The following is a description of a gene set: Mouse Gene Set: GOCC_DENSE_BODY An electron dense body which may contain granules. species: Mus musculus, and this is the list of marker genes: Sybu, Piwil1, Snd1 (staphylococcal nuclease and tudor domain containing 1), Piwil2, Actg1, Actb, Trf